The following is a description of a gene set: studied in species Mus musculus Mouse Gene Set: GOMF_NFAT_PROTEIN_BINDING Binding to NFAT (nuclear factor of activated T cells) proteins, a family of transcription factors. NFAT proteins have crucial roles in the development and function of the immune system., and this is the list of marker genes: Ppara, Spi1, Foxp3, Gata6, Mapk14, Gata4